Given this list of marker genes C1qtnf4, Peli3, Mettl3, Il1r2, Sharpin, Cd74, Trim41, Otulin, H2bc21, Irak1, Gas6, Irf7, Smim30, Vrk2, Palm3, Nlrp6 (NLR family, pyrin domain containing 6), Gps2, Casp1 (NCBI Gene Id 12362), Ripk1, Ptpn2, Parp9, Taf9, Irak2, Tle5, Ythdf2, Mul1, Traf2, Wnt5a, Ecm1, Mapk7, Ticam2, Rabgef1, Slit2, Cd40, Tank, Igtp, Tlr2, Cpne1, Otop1, Tnfrsf1a, Il6, Mavs, Naip5, Angpt1, Sh2b3, Apoa1, Csf1, Nol3, Adam17, Birc7, Tlr4, Spata2, Dicer1, Ythdf3, Usp27x, Il36rn, Cnot7 (NCBI Gene Id 18983), Cish, Oas1b, Xiap (X-linked inhibitor of apoptosis), Cxcr4 (C-X-C motif chemokine receptor 4), Traip, Ext1, Oas1f, F2rl1, Rnf185, Oas1d, Usp29, Rnf113a2, Il7, Ptprf, Samhd1, Il6st, Rnf113a1, Ikbke, Stat2, Axl, Irak3, Gfi1, Stap1, Txk, Usp18, Naip1, Isg15, Gigyf2 (GRB10 interacting GYF protein 2), Adipoq, Pycard, Slit3, Oas1c, Hif1a, Pias4, Cdc37, Trim6, Cav1, Pafah1b1, Arg1, Oas1g, Irf3, Zbp1, Tmc8, Laptm5, Mmp8, Trim56, Sigirr, Map2k5 (NCBI Gene Id 23938), Cactin, Tjp2, Il1rn, Nr1h4, Naip6, Cyld, Ppp2cb, Oas1a, Lsm14a, Irgm2, Oas1h, Adar, Trem2, Fadd, Eif4e2, Oas1e, Irgm1, Cd300lf, Edn1, Trim44, Hpx, Cldn18, Prkn, Parp14, Ccl5, Med1, Otud4, Crebrf, Nkiras2 (NCBI Gene Id 75157), Rbm47, Trex1, Ifih1, Sphk1, Mmp12, Rffl, Syk, Klf4, Rigi, Ptprc, Dcst1, Pias3, Ube2k, Sting1, Pparg, Cd24a, Tbk1, Usp25, Hspa1b, Oas3, Naip2, Trim32, Padi2, Tnfrsf11b, Ccdc3, Ripk2, Ttll12, Nkiras1, Robo1, Tslp, Casp4, Il1r1, Nlrc5, Dhx9, Hipk1, Dnaja3, here is a description of the gene set: Any process that modulates the rate, frequency, or extent of a response to cytokine stimulus. Mouse Gene Set: GOBP_REGULATION_OF_RESPONSE_TO_CYTOKINE_STIMULUS species: Mus musculus